The following is a description of a gene set: Mouse Gene Set: GOMF_SODIUM_CHANNEL_ACTIVITY studied in species Mus musculus Enables the energy-independent facilitated diffusion of a sodium ion through a transmembrane aqueous pore or channel., and this is the list of marker genes: Slc4a11, Scn2b, Fxyd3, Cacna1h, Scnn1g, Mcoln3, Grin1, Asic4, Commd1, Gria2, Hcn2, Fgf14, Grik1, Nedd4, Scn11a, Tmem168, Pkd2, Rangrf, Tpcn2, Fgf12, Scn10a, Hcn4, Grik2, Grik3, Scn2a, Scn4b, Gpd1l, Fxyd7, Fgf13, Nos1, Asic3, Sclt1, Asic5, Glrx, Mcoln1, Scn8a, Cnga3, Scn7a, Scn1b, Kcnk1, Scn5a, Fgf11, Camk2d, Scn4a, Asic2, Trpv3, Ptpn3, Scnn1b, Scn9a, Fxyd1, Tpcn1, Pkd2l1, Cnga1, Grik4 (glutamate receptor, ionotropic, kainate 4), Fxyd4, Fxyd2, Tmprss3, Snta1, Kcnk3, Trpm5, Trpm2, Kcnk9, Pcsk9, Scn1a, Fxyd5, Hcn1, Hcn3, Fxyd6, Ywhah, Scnn1a, Scn3a, Atp2b4, Gpld1, Agt, Scn3b, Cacna1g, Asic1, Cacna1i (calcium channel, voltage-dependent, alpha 1I subunit), P2rx7, Prss8, Nedd4l, Prss30, Cav3, Grik5, Nalcn